Given this list of marker genes RAC1, KRT1, CASP6, NME1, EVPL, NME2, MCL1 (NCBI Gene Id 4170), ARHGDIA, MAPK6, XRCC1, DSG1 (desmoglein 1), DAPK1, RND3, HOXD3, PTPRF, TRAF3, TNFRSF10A, CDKN1A, CASP4, PGF, TIMP1, TRAIP, PRODH, TRIP6 (NCBI Gene Id 96624), DSP, GADD45A, SEPTIN7, CASP10, SEPTIN2, CDC37, CD9, CYTH2, PLAT, ERCC1, here is a description of the gene set: Ultraviolet B irradiation initiates and promotes skin cancers, photo-aging, and immune suppression. In order to elucidate the effect of these processes at the level of gene expression, we used cDNA microarray technology to examine the effect of ultraviolet B irradiation on 588 cancer-related genes in human keratinocytes at 1, 6, and 24 h post-irradiation with a mildly cytotoxic dose of ultraviolet B (170 mJ/cm(2)). The viability of the irradiated keratinocytes was 75% at 24 h post-irradiation. Various cytokeratins and transcription factors were up-regulated within 1 h post-irradiation. After 6 h, expression of a variety of genes related to growth regulation (e.g. p21(WAF1), notch 4, and smoothened), apoptosis (e.g. caspase 10, hTRIP, and CRAF1), DNA repair (ERCC1, XRCC1), cytokines (e.g. IL-6, IL-13, TGF-beta, and endothelin 2), and cell adhesion (e.g. RhoE, and RhoGDI) were altered in human keratinocytes. These data suggest the changes in a cascade of gene expression in human keratinocytes occurring within 24 h after UVB exposure. Although the roles of these cellular genes after UVB-irradiation remain to be elucidated, microarray analysis may provide a new view of gene expression in epidermal keratinocytes following UVB exposure. from publication Murakami T, Fujimoto M, Ohtsuki M, Nakagawa H (PMID 11532376) Human Gene Set: MURAKAMI_UV_RESPONSE_6HR_UP species: Homo sapiens Genes up-regulated in primary keratinocytes at 6 h after UVB irradiation.